The following is a description of a gene set: Human Gene Set: REACTOME_INTERCONVERSION_OF_NUCLEOTIDE_DI_AND_TRIPHOSPHATES species: Homo sapiens Interconversion of nucleotide di- and triphosphates, and this is the list of marker genes: TYMS, RRM2, CTPS1 (CTP synthase 1), AK1, CTPS2, CMPK1, DCTPP1, NUDT13, AK8, NME2, AK2, GSR, AK9, RRM2B, AK5, AK6, TXN, GLRX, NME4 (NME/NM23 nucleoside diphosphate kinase 4), DUT, TXNRD1, GUK1, RRM1, AK4, NME3 (NCBI Gene Id 96012), DTYMK, NME1, DCTD, AK7